Given this list of marker genes Atp5mk, Sh3bgrl3, Ifi27l2a, Pfn1, H2-Aa, Tmsb10, here is a description of the gene set: Genes positively differentially expressed in cell type: MigDC (migratory dendritic cell) upon treatment with cytokine: CD30L in mouse lymph nodes in vivo. Cytokines mediate cell-cell communication in the immune system and represent important therapeutic targets. A myriad of studies have highlighted their central role in immune function, yet we lack a global view of the cellular responses of each immune cell type to each cytokine. To address this gap, the authors created the Immune Dictionary, a compendium of single-cell transcriptomic profiles of more than 17 immune cell types in response to each of 86 cytokines (>1,400 cytokine-cell type combinations) in mouse lymph nodes in vivo. A cytokine-centric view of the dictionary revealed that most cytokines induce highly cell-type-specific responses. For example, the inflammatory cytokine interleukin-1β induces distinct gene programmes in almost every cell type. A cell-type-centric view of the dictionary identified more than 66 cytokine-driven cellular polarization states across immune cell types, including previously uncharacterized states such as an interleukin-18-induced polyfunctional natural killer cell state. from publication Cui A, Huang T, Li S, Ma A, Pérez JL, Sander C, Keskin DB, Wu CJ, Fraenkel E, Hacohen N (PMID 38057668) Mouse Gene Set: CUI_MIGDC_CD30L_RESPONSE_UP species: Mus musculus